The following is a description of a gene set: Mouse Gene Set: GOBP_ENTEROENDOCRINE_CELL_DIFFERENTIATION species: Mus musculus The process in which a relatively unspecialized cell acquires specialized structural and/or functional features of an enteroendocrine cell. Enteroendocrine cells are hormonally active epithelial cells in the gut that constitute the diffuse neuroendocrine system., and this is the list of marker genes: Pdpk1, Ier3ip1, Pax4, Onecut1, Nkx6-1, Percc1 (proline and glutamate rich with coiled coil 1), Rbm4, Bmp6, Mir503, Smo, Sidt2, Men1, Bhlha15, Clock, Dll1, Cftr, Wnt5a, Pdx1, Mir375, Nkx6-3, Bmp4, Rfx3, Nkx2-2, Bmal1, Rheb, Ascl1, Vhl, Cdh2, Rfx6, Mir214, Bmp5, Cdk6, Gata6, Mir7-1, Reg1, Bad, Hes1, Mir541, Insm1, Gdf11 (growth differentiation factor 11), Nkx6-2, Neurod1, Pax6